The following is a description of a gene set: from publication Collison LW, Chaturvedi V, Henderson AL, Giacomin PR, Guy C, Bankoti J, Finkelstein D, Forbes K, Workman CJ, Brown SA, Rehg JE, Jones ML, Ni HT, Artis D, Turk MJ, Vignali DA (PMID 20953201) Genes down-regulated in control T conv versus resting T reg cells. Regulatory T cells (Tregs) play a critical role in the maintenance of immunological self-tolerance. Naïve human or murine T cell treatment with the inhibitory cytokine IL35 induces a regulatory population, termed iTR35, that mediates suppression via IL35, but not IL10 or TGFβ, neither express nor require Foxp3, are strongly suppressive in five in vivo models, and exhibit in vivo stability. Treg-mediated suppression induces iTR35 generation in an IL35- and IL10-dependent manner in vitro, and in inflammatory conditions in vivo in Trichuris-infected intestines and within the tumor microenvironment, where they appear to contribute to the regulatory milieu. iTR35 may constitute a key mediator of infectious tolerance and may contribute to Treg-mediated tumor progression, and ex vivo-generated iTR35 may possess therapeutic utility. Human Gene Set: GSE24210_TCONV_VS_TREG_DN studied in species Homo sapiens, and this is the list of marker genes: HEBP1, TFPT (NCBI Gene Id 29844), ZC3H12C, PRSS23, AVPR1B, PLIN3, PTPRJ, SEC61G, LRRC75A, CHEK2, BBS2, ZEB1, OBI1, ROBO3, IRF6, NUSAP1, IFI44L, TMEM230, PRPF3, TOR3A, HAVCR1, NOB1, NUBPL, PIP4P2, CD300LF, NME7, CA13, REC8, STX2, KYAT3, WIPF2, BMAL1, AP5B1, ATP1B4, COMMD7, IFI44, AFP, SLC2A9 (NCBI Gene Id 56606), RHBDL2, ZNHIT2, KICS2 (NCBI Gene Id 144577), ADPRM, DGLUCY, PTGES2, ZNF43, UFSP2, TGM2, PCDHB14, TUSC3, BCL2L2, MTNAP1, KPNA2, HERC4, DAP, PLPP1 (phospholipid phosphatase 1), TSPAN31, AKT1S1, RXYLT1, GCLM, CSF2, PPL, F2RL1 (NCBI Gene Id 7901), MEPCE, ADCY6, DDX60, FLG, SMPD4, GALNS, RAB37, DYNLT2B, PLCG1, RNF157, GMDS, TOP1MT, FAM185A, GSPT1, PRNP, ZMAT3, FKBPL, CCNA2, TMBIM1 (transmembrane BAX inhibitor motif containing 1), HDAC9, HADH, UBL5, ARHGEF6 (NCBI Gene Id 9459), MRPL17, PPP1R15B, NCEH1 (NCBI Gene Id 57552), ALAD, FAM120AOS, SLC46A1, MS4A7, RNF130, SLC66A2 (NCBI Gene Id 80148), BID (BH3 interacting domain death agonist), NRP1, CENPH, MTFMT, GPR84, PHF2, CRIM1, CENPK, GRAMD1C (GRAM domain containing 1C), TYMS, TMEM154, FARP2, IFT172, GPI, GALK1 (NCBI Gene Id 2584), BAG2, PEX16, ATXN1, SPINDOC, NKAIN2, PEA15, FNBP4, RTN1, B3GNT2, SELENOH, NLRX1 (NCBI Gene Id 79671), CD99L2, TMEM107, ANGEL1, MAP3K20, COL19A1, SRPX, SLC39A14, TERB1, MRAS, DRAM2, WNT4, ABHD4, TFCP2L1, ZNF426, MAN1C1, MRPL12, NRAP, ARHGAP21, RHBDD1, KLHL12, SENP8, MZT2B, SLC35D2, CLIP1, GLT8D1 (glycosyltransferase 8 domain containing 1), PGM2, MRPS2, FAM210A, MCAM, FECH, EPHX2, CIBAR1, MNS1, CENPS, GXYLT1, LINS1, NAA25, RSPH1, MZT1, TBC1D19, RLBP1, ST7L, TSGA13, CLCA1, MTX3, SKA1, SYCE2, HNRNPLL, FARS2, SEMA4B, CDKN3, FGFBP1, TPI1, HMBS, CHAMP1, SLFNL1, GAR1, PITHD1, MRPS5, NFIX, SPSB3 (splA/ryanodine receptor domain and SOCS box containing 3), EFCAB11, MGLL, SPIC, CNMD, TRMT5, IL9R, SLC39A4, TTC12, JCHAIN, PHF10, TPRKB, MGAT4B, BAZ1A, ALDOC, CDC25A, CSF3, CACNB4, SLC41A2 (NCBI Gene Id 84102), RABGGTB